The following is a description of a gene set: During telophase, the double membrane of the reforming NE, which is derived from fenestrated sheets and tubules of the mitotic ER, is sealed to reestablish the nucleocytoplasmic permeability barrier. Some of the holes in the reforming nuclear envelope close around forming nuclear pore complexes (NPCs). Other fenestrations are sealed by the formation of filamentous ESCRT-III assemblies and their disassembly by the AAA+ ATPase VPS4 (VPS4A/VPS4B). The ESCRT-III/VPS4 machinery has a general role in “reverse topology” membrane scission (i.e., involving the fusion of cytoplasmic membrane surfaces. In concert with these events, microtubules connected to the kinetochore and to other chromosomal regions are severed. species: Homo sapiens part of: Nuclear Envelope (NE) Reassembly Reactome Pathway: Sealing of the nuclear envelope (NE) by ESCRT-III, and this is the list of marker genes: TUBB8B, TUBA3C, CHMP2A, LEMD2, CHMP2B, TUBB2A, CHMP6, TUBA3E, VPS4A, TUBA4B, TUBA1B, TUBA1A, TUBB1, CHMP4B, SPAST, CHMP3, TUBB8, TUBB2B, TUBB4A, TUBB3, TUBB4B, CC2D1B, TUBA1C (tubulin alpha 1c), TUBB6, CHMP4C, TUBA8, CHMP7, CHMP4A, TUBAL3, TUBA3D, IST1, TUBA4A